The following is a description of a gene set: studied in species Homo sapiens A protein modification process in which one or more groups of a small protein, such as ubiquitin or a ubiquitin-like protein, are covalently attached to a target protein. Human Gene Set: GOBP_PROTEIN_MODIFICATION_BY_SMALL_PROTEIN_CONJUGATION, and this is the list of marker genes: UBE4B, COPS9, ASB17, FBXO4, WDR77, PRMT3, PIAS2, RNF187, UBB, MKRN3, ZNRF4, ZNRF1, FBXO38, URM1, COPS7B, PEX2, ANKRD9, MIB1, MSL2, SPOPL, KLHL13, THOP1, WFS1, PRAMEF9, MOCS3, UBR1, UBE2D3, KLHL17, NEUROD2, RPS2, SMC5, LNPEP, BAG2, HECTD3, MED1, EGR1, CTU2, KLHL40, NEDD4, RNF185, MKRN1, FAU, ATG10, UNKL, COPS3, MED27, SH3RF1, NEURL3, AXIN1, NUB1, SOCS5, LZTR1, DCAF1, BFAR, TNKS2, DTX3L, GNL3, RNF39, RNF227, MARCHF7, TRIM3, SPOP, MARCHF4, LMO7, PML, OS9, HECTD1, SOCS1, UBE3B, MED12, CUL1, RCHY1, RAB40AL, KBTBD13, TRIM28, BRCA1, PCNP, UBR3, TRPM4, HECTD2, TBC1D7 (NCBI Gene Id 51256), KLHL22, HECW2 (HECT, C2 and WW domain containing E3 ubiquitin protein ligase 2), USP9X, ANAPC4, PPIL2, RFFL, MARCHF8 (membrane associated ring-CH-type finger 8), RNF14, ERCC8, DCAF7, TRIM58, RNF182, RIPK2, ARIH1 (NCBI Gene Id 25820), JADE2, PIAS3, KDM1A, NAE1, CDC20, MGRN1, NXN, EID3, NDP, RNF144B, UBR5, BEX2, HACE1, ITCH, UBE2A, TRIM40, SOCS3, CCNB1IP1, COPS7A, RAB40C, BAG5, USP5, TRIM5, PTTG1IP, RAD18, SUMO1P1, RNF125, CUL3, ANAPC5, ASB10, USP4, TRIM42, VCP, DCAF8, PRKN, TICAM1, FBXL15, IRF2BPL, HSPA5, UBE2QL1, NEURL1, MDM4, AMFR, BIRC6, VPS11, DCAF17, PRICKLE1, TAF1, NHLRC1, DDA1, OTULIN, EGR2, FBXO31, DDRGK1, CENPS, SLF1, KCTD21, DTL, FBXW7, HUWE1, DTX3, FBXO7, TRIM13, UBAC1, ABCB11, CDC34, ANAPC11 (anaphase promoting complex subunit 11), DTX1, FEM1C, LRRK2 (NCBI Gene Id 399472), RPS27A, RNF121, RAB40B, SOCS2, RNF146, RNF122, SYVN1, RANBP2, TRIM52, ENC1, COPS8, MAGEL2, TGFBR1, KLHL9, SENP5, RNF133, SHARPIN, SASH1, FBXO32, SENP1, XIAP, WDR48, MED11, TRAF3IP2, ARRDC1, UBE3D, HMG20A, KLHL10, NPEPPS, TRIM27, CBFB, SMC6, ADGRB1, NT5C2, CDK5RAP3, ASB7, EIPR1, RACK1 (NCBI Gene Id 90938), TRIM55, RNF7, NPM1 (NCBI Gene Id 4869), RBCK1, TRIM31, RFWD3, MALT1, SUMO3, SKP1, RING1, TRIM7, RNF223, CUL2, UBE2V1, UBE2E2, RNF44, BIRC8, NFE2L1, PEF1, MIR138-1, TULP4, FYN, TRIM44, SENP6, DCAF16, RNF5, FBXL2, TRIM8, KCTD11, PJA1, MTA1, HIF1A, RNF183, RBBP6, RNF111, RNF20, GSK3A, FBXL5, MARCHF3, LRRC41, PLK1, PRPF19, IFI27, KLHDC10, CBL, TRIML1, ZNF738, RNF11, CTNNB1, RNF8, SEPTIN4 (NCBI Gene Id 5414), GABARAP, ARIH2, MTBP (NCBI Gene Id 27085), DZIP3, CUL4B, CBX4, FREY1, APPBP2, PAXIP1, NQO1 (NCBI Gene Id 4834), HMG20B, UFL1, ATG7, KLHL20, WDTC1, EPAS1, GMCL2, RNF144A, SENP2, MARCHF9, WASHC1, CBLL1, KLHL25, KBTBD8, HSP90AA1, FBXO30, FBXO45, IRF2BP1, MED17, TRIP12, TRIM21, RNF212B, UBD, BIRC2, COPS6, ARRB2, FBXO24 (F-box protein 24), DTX4, RNF167, LRR1, ARRB1, RNF180, CUL9, PABPN1L, MAGEC2, BTBD1, SDE2, CDCA3, RC3H1, CHFR, WSB2, ASB13, SHPRH, MARCHF11, ASB14, COPS5, KLHL41, TRIM63, DCAF5, IFT80, ASB18, UBE2M, SUMO2, ANAPC7, RNF13, DCAF11, TTC3, MDM2, ZNRF2, CBLB, PRKCE, UBE4A, TRIM39, CAND2, RNF43, RNF128 (NCBI Gene Id 79589), RNF138, DCUN1D1, FAM107A, KBTBD2, UBE2J2, TRIM24, HERC1, ZNF598, IVNS1ABP, UBE2D1, RNF34, FANCI, MED8, PINX1, RUSC1, TRIM45, ASB3, SMURF1, ZMIZ1, HDAC3, CDC23, UBE2D4, ASB5, SUMO1, DAW1, TMEM129, ANAPC16, MEGF8, ATG5, KLHL18, UBE3A, RPS7, DCUN1D3, COPS4 (COP9 signalosome subunit 4), SKP2, RLIM, TRIM59, KLHL8, RNF212, KEAP1, PINK1, KBTBD7, TRIM65, UBE2E3, COPS2, VPS18, CEP63, NDFIP2, TSPO, MAGEF1, CISH, UCHL3, CCAR1, KLHL36, FBH1, CBLL2, VPS28, CHP1, DDB2, HDAC4, KCMF1, ANAPC2 (NCBI Gene Id 29882), RNF19A, HECTD4, ASB4, HDAC8, ARRDC4, KLHL2, MED31, PPIA, EPM2A, NHLRC3, TPP2, PEX12, FBXL3, MYCBP2, TRIM26, SPHK1, TRAF2, WSB1, TNFAIP1, NEURL2, ASB9, ISG15, UBQLN1, WWTR1, WDSUB1, RNF170, TRIM9, UBOX5 (NCBI Gene Id 494512), TRIM35, TRIM38, RNF2, TRIM17, KIAA1586, RWDD3, ASB6, FBXO5, SLF2, BMI1, STUB1, SOCS4, RAG1, KBTBD6, ELOB, CDC16, UBE2NL, TRIM37, FOXF2, ANAPC13, TSPYL5, SIRT7, RAB40A, UBE2L3, SIRT1, DERL1, ZMIZ2, DTX2, BIRC3, HLTF, SPSB3, NOD2, ARK2C, IFIH1, DCUN1D4, NGF, TRIM2, RPL23, UBE2I, ZNRF3 (zinc and ring finger 3), CEP78, RNF152, GNL3L, N4BP1, ASB12, SOCS7, MID2, BLMH, KLHL12, KLHL42, RPGR, HERC2, ZBED1, TRIM34, FANCM, RBX1, AMBRA1, SOCS6, SMURF2, DNAJA3, FBXL7, RNF216, VCPIP1 (valosin containing protein interacting protein 1), E4F1, FANCL (NCBI Gene Id 55120), BEX4, WDR24, FBXO43 (NCBI Gene Id 286151), FBXW8, MED6, RNF31, RNF113A, ZBTB16, CRBN, FSCB, UBE2J1, MARCHF6, TRIM62, RNF186, PCMTD1, PER2, RNF217, G2E3, PDZRN3, ZNF451, WBP1L, RNFT1, WWP1, KLHDC2, ASB15 (ankyrin repeat and SOCS box containing 15), UBE2K, PARP10, BARD1, ABL1, HERC6, CBLC, UBC, TRPC4AP, SPSB1, DNAJB2, RNF166, TRIM47, ZFP91, ZC4H2, TOPORS, CCNF, NEDD4L, HSP90AB1, DNAJA1, FBXO25, FBXO6, OGT, HAMP, HDAC6, RNF115, DDB1, CENPX, TOLLIP, RANGAP1, ASB1, COP1, LTN1, COMMD1, MINAR1, UBE2U, RASSF5, CRY1, MUL1, UBR2, MAD2L2, SAE1, AIMP2, SPSB4, DCAF15, RNF103, CDC26, GCLC, ASB11, RNF126, ARNT, CDKN2A, ARRDC3, ANGPT1, U2AF2, UBE2Q2, UFM1, UBE2D2, UBA5, KCTD10, RNF25, FEM1A, NSMCE4A, ELOC, UBA7, FBXL17, HERC3 (NCBI Gene Id 9838), UBA52, MAD2L1, PELI1, KLHDC1, TRIM32, EYA1, RNF149, LNX1, BEX1, USP7, RNF6, KLHL24, CNOT4, RNF10, TRIM4, KLHL7, RPL5, NFATC2IP, DCAF13, UBR7, FZR1, RMND5A, C10orf90, MED10, USP44, PRKCG, RNF220, FBXW5, PIAS1, CAND1, UBE2F, ASB16, FBXO22, WNK1, ASB2, KLHDC3, UBA1, HERC2P3, UBE3C, TRIM71, UBE2O, RNF40, DCUN1D2, PDCD6, PEX10, PRAME, PJA2, ZC3HC1, CTU1, RC3H2, ANAPC10, ANAPC1, AREL1, RNF139, KLHL21, UBE2E1 (ubiquitin conjugating enzyme E2 E1), CDK5, RNF19B, UBE2C, BEX3, DCUN1D5, GTPBP4, PLAA, TRIM23, FBXL12, MARCHF2, BTRC, RNF26, RPS3 (ribosomal protein S3), FBXW12, TNKS, CAPN3, HERPUD1, ATG3, ZSWIM8, RASD2, RNF38, UBXN2A, PELI2 (NCBI Gene Id 93480), MAPK9, FBXW11, VHL, ZSWIM2, PARK7, NDFIP1, DCAF4, LRSAM1, SVBP, MARCHF1, UBA2, UFSP1, CDC14B, RNF225, RNF228, RNF123 (NCBI Gene Id 63891), PSMD10, MED30, TRIM68, PTPN22, PHRF1, TCF25, HSPBP1, UBA6, TNFAIP3, KLHL15, AMER1, FBXO3, INAVA, DDX3X, MED21, UBE2N, FBXO11, CAV1, FBXO33, SIAH1, RNF130, TRIM11, AKTIP, RNF181, UHRF1, PPP1R11, TRIM41, RNF4, RNF169, HECW1, STX1A, RPL11, FBXO2, ANAPC15, UBR4, NFX1, RNF168, CUL5, NSMCE3, DCAF12, TRAF7, SPRTN, SIAH2, MARCHF10, NFE2L2, SUMO4, AKT1, FEM1B, UBE2T, UBE2R2, RNF213, TRAIP, CAMLG, OBI1, MARCHF5, FBXO28, HSPA1B, GPS2, HERC4, SPRY2 (NCBI Gene Id 10253), DCAF10, CUL4A, UBE2W, UBE2S, MAGEA2B, ANKIB1, TRIM6, CUL7, MED7, FBXL21P, TRIB3, PIAS4, MAGEA2, DAXX, PELI3, BCL11A, WWP2, NBN, LAPTM5, RNF114, PHF23, KCTD13, NMI, KCTD9, NSMCE1, FBXL22, PRAMEF6, RNF41, DET1, UVSSA, TRIM22, RNF141, GPS1, KCTD6, UBE2G1, TRIM25, GAN, SQSTM1, DCST1, MARCHF6-DT, UHRF2 (NCBI Gene Id 49857), UBE2H, RELA, MIR101-1, NEURL1B, RASSF1 (NCBI Gene Id 11186), UBA3 (NCBI Gene Id 9039), BRAP, HDAC7, DCAF6, UBE2L6, RNF112, UBE2L5, UBE2G2, FBXO9, BCL10, ASB8, SH3RF2, NSMCE2, RNF208, BIRC7, TRIM33, TTC36, MIB2, TRIM56, NEDD8, MYLIP, HSPA1A, UBXN1, TRIM69, UBE2V2, RNF135, MKRN2, GSK3B, TRAF6, BCL2, UBE2Z, SPSB2, FBXO10, KLHL3, TRIML2, UBE2Q1, CDC27, UFC1, RNF157, SH3RF3, UBE2B, HERC5